Given this list of marker genes Elane, Tac1, Tslp, Cotl1, Gapdh-ps15, Mpo, Pomc, Malt1, Clec4n, Ang, Atg5, Clec4d, Clec4e, Spi1, Bak1, Rarres2, Gapdh, Ang2, Clec4b1, Clec4a1, Syk, Ltf, Gapdhrt, Ctsg, Tgfb1, Spon2, Npy (neuropeptide Y), Leap2, Il17a, Spag11a, Scimp, Tlr2, Btk, Usp15, Clec7a, Trim62, Ang6, Gapdhrt2, Il17ra, Pik3cd, App, Fam3a, Gpr15lg, Cxcl1, Ncf1, Zbp1, Arg1, Ptx3 (NCBI Gene Id 99687), Clec4b2, Clec4a3, Hamp2, Jagn1, Ang5, Gm12250, Crk, Clec4a2, Hrg, Myd88, Defb42, Card9, Il25, Il17rc, Slc22a19, Cd209b, Hamp, Il36rn, Cx3cr1, Plcg2, Nlrp10, Clec4a4, Bcl10, Camp, Defb19, Pla2g5, Ang4, Vip (vasoactive intestinal polypeptide), here is a description of the gene set: Mouse Gene Set: GOBP_RESPONSE_TO_FUNGUS Any process that results in a change in state or activity of a cell or an organism (in terms of movement, secretion, enzyme production, gene expression, etc.) as a result of a stimulus from a fungus. species: Mus musculus